The following is a description of a gene set: from publication Yamada T, Park CS, Mamonkin M, Lacorazza HD (PMID 19412182) Human Gene Set: GSE15324_ELF4_KO_VS_WT_NAIVE_CD8_TCELL_UP Transcription factors that regulate quiescence, proliferation, and homing of lymphocytes are critical for effective immune system function. In the present study, we demonstrated that the transcription factor ELF4 directly activates the tumor suppressor KLF4 downstream of T cell receptor (TCR) signaling to induce cell cycle arrest in naive CD8+ T cells. Elf4- and Klf4-deficient mice accumulated CD8+CD44hi T cells during steady-state conditions and generated more memory T cells after immunization. The homeostatic expansion of CD8+CD44hi T cells in Elf4-null mice resulted in a redistribution of cells to non-lymphoid tissue due to reduced expression of the transcription factor KLF2, and the surface proteins CCR7 and CD62L. This work describes the combinatorial role of lymphocyte-intrinsic factors in the control of T cell homeostasis, activation and homing. species: Homo sapiens Genes up-regulated in comparison of naive CD8 T cells from ELF4 defficient mice versus those from wild type animals., and this is the list of marker genes: HEXD, ACP2, CTSG, COL13A1, CCDC102A, BMPR2, HMMR, BAIAP3, PLCZ1, EPHX3, PURG, CD93, ACSBG1, LZIC, SPOCK2, TMED1, PDX1, KIF13B, GPR83, GPM6B, TSPAN5, SPATA24, ITGAX, KYAT3, IMMP2L, CTHRC1, BIRC5, TAF15, CCNB2, ZBTB48, SLC18B1, PLD2, RASGRP4, AGRN, FAM86B2, OSBPL3, STAU2, TET1, KIF5C, PHLPP2, UNC5CL, TMEM184B (NCBI Gene Id 25829), DCUN1D4, CCR5, SRGAP3, SLAMF7, FRMD4B, GPC1, CDCA8, TRPM5, RASSF3, IGF1, BAIAP2, PRICKLE3, C11orf24 (chromosome 11 open reading frame 24), C11orf91, RPS6KA2, PEA15, RITA1, DAPK2, POU1F1, FAM43B, TCEAL8, BHLHE22, C14orf28, ASPM, RARG, SPC25, SNHG7, IFITM2, PTGFRN, PATL2, LRGUK, SH3BP5L, ALDH7A1, SPRED3, MACROD2, DIP2C, WDFY1, FAM210A, CSNK1E, TTL, MSLN (mesothelin), CRACDL, PACC1, GALNT9, ALG2, CCDC61, GPAT3, ITGB3, CMPK2, NTF4, LANCL2, TTC23L, PLEKHB2, TEX9, CFAP418, PLTP, SRSF12, NDRG4, IPO13, RBM6, ZCCHC3, TEX15, TBC1D17, RHOF (ras homolog family member F, filopodia associated), WFS1, IKZF2, PLAC8L1, MTNR1A, RGS11, B9D1, GCAT, MORN2, SMPDL3B, MFSD8, FARP2, ENPP5, VRTN, CHRNB1, STEAP1, PIK3R2, PDCD1, IFIT3, NKAIN4, NINL, TP63, VPS9D1, OPLAH, PWWP2A, CNRIP1, ACSL3, IL17RC, GKAP1, GRHL1, FAM241B, GSAP, SYDE1, ABCA2, NDRG1, ERMN, MITF, MMUT, VSTM2A, KIF7, ENKD1, PPFIA2, HYAL2, SLC25A35, CRAT, NICN1, SLC66A1, TNFSF4, EVI5L, LEFTY2, RPS6KC1, ARSB, CD163, COL5A2, RAB4A (RAB4A, member RAS oncogene family), IKZF4, NENF, G0S2, CX3CR1, TFPI, PRDM8, LMO1, TOM1L2, UBE2C, ZBTB39, PCBP3, RPS6KA5, RO60, RNF24, SLC6A14, CDH1, MT3, C1orf21, CHPT1, IFI27L2 (NCBI Gene Id 83982), IQCC, SORD, NPDC1, CENPK, DCLK1, SNX20, SLC22A17, TMEM184A, DNA2, ENOX2, TNS2, RRM2, PDLIM7, SLC27A4, TNFRSF25, ADAT2, FAM220A, IRGQ, PANK1, TBC1D22B